The following is a description of a gene set: Human Gene Set: ELLWOOD_MYC_TARGETS_UP Increased Myc gene copy number is observed in human prostate cancer. To define Myc's functional role, we generated transgenic mice expressing human c-Myc in the mouse prostate. All mice developed murine prostatic intraepithelial neoplasia followed by invasive adenocarcinoma. Microarray-based expression profiling identified a Myc prostate cancer expression signature, which included the putative human tumor suppressor NXK3.1. Human prostate tumor databases revealed modules of human genes that varied in concert with the Myc prostate cancer signature. This module includes the Pim-1 kinase, a gene known to cooperate with Myc in tumorigenesis, and defines a subset of human, Myc-like human cancers. This approach illustrates how genomic technologies can be applied to mouse cancer models to guide evaluation of human tumor databases. Genes up-regulated in transgenic mice expressing human MYC in prostate. studied in species Mus musculus from publication Ellwood-Yen K, Graeber TG, Wongvipat J, Iruela-Arispe ML, Zhang J, Matusik R, Thomas GV, Sawyers CL (PMID 14522256), and this is the list of marker genes: CLCN1, UCK2, CCDC93, RPL37A, SPATS2, PIGK, BAG2, LY6D, DPP7, RGS19, HSD17B12, PPP1R18, ECE1